Given this list of marker genes ENSG00000233251, CD300LG, PRND (NCBI Gene Id 23627), MADCAM1, APLN, GUCY1B2, C1QTNF9, APLNR, TM4SF18, SLC9C1, ESM1, BTNL9, ENSG00000243273 (novel transcript), DYNLT5, TCF4-AS1, QRFPR, DLL4, PKD1L1, CA4, LINC01594, ENSG00000253348, SELE, TMC1, OPN5 (NCBI Gene Id 221391), LRRC77P, here is a description of the gene set: from publication Cao J, O'Day DR, Pliner HA, Kingsley PD, Deng M, Daza RM, Zager MA, Aldinger KA, Blecher-Gonen R, Zhang F, Spielmann M, Palis J, Doherty D, Steemers FJ, Glass IA, Trapnell C, Shendure J (PMID 33184181) Human Gene Set: DESCARTES_FETAL_HEART_VASCULAR_ENDOTHELIAL_CELLS The gene expression program underlying the specification of human cell types is of fundamental interest. The study authors generated human cell atlases of gene expression and chromatin accessibility in fetal tissues. For gene expression, the study authors applied three-level combinatorial indexing to >110 samples representing 15 organs, ultimately profiling ~4 million single cells. The study authors leveraged the literature and other atlases to identify and annotate hundreds of cell types and subtypes, both within and across tissues. Our analyses focused on organ-specific specializations of broadly distributed cell types (such as blood, endothelial, and epithelial), sites of fetal erythropoiesis (which notably included the adrenal gland), and integration with mouse developmental atlases (such as conserved specification of blood cells). These data represent a rich resource for the exploration of in vivo human gene expression in diverse tissues and cell types. species: Homo sapiens Marker genes curated from the annotated cluster as represented in the Descartes Human Gene Expression During Development database.